The following is a description of a gene set: Genes predicted to be targets of miRBase v22 microRNA hsa-miR-4780 in miRDB v6.0 with MirTarget v4 prediction scores > 80 (high confidence targets). species: Homo sapiens Human Gene Set: MIR4780 from publication Chen Y, Wang X (PMID 31504780), and this is the list of marker genes: SLC12A2, ASCL2, TMEM191B, PPP1R14C, SKI, GPBP1L1, FOXN2 (forkhead box N2), RNF169, HEXIM1, GMFB, ADRA1A, KLHL3, CLVS1, VWA2, TMTC3, TMED4, NUDT7, MMP19, TMEM156, BBS7, SCAF11, YAP1, MINAR1, TMEM191C, TLE4, TRIM44, YBX2, ATXN7, SORCS3, DYRK3, PHF6, PIK3C2B, MFAP5 (NCBI Gene Id 8076), STT3B, FUT10, RANBP1, PCMT1, PTBP3, BBS5, NCL, HNMT, NOP58